Given this list of marker genes ZIC3 (NCBI Gene Id 7547), MPI, CMIP, ZIC2, PLXNA4, FAM53B, AIPL1, DCANP1, CNBP, SKI, SIK3, TBC1D2B, NRGN, DAGLA, CERS1, here is a description of the gene set: species: Homo sapiens Human Gene Set: MIR564 from publication Chen Y, Wang X (PMID 31504780) Genes predicted to be targets of miRBase v22 microRNA hsa-miR-564 in miRDB v6.0 with MirTarget v4 prediction scores > 80 (high confidence targets).